Given this list of marker genes Rapsn, Stxbp1, Rab3a, P2rx3, Fchsd2, Rimbp3, Ntf3, Etv5, Fchsd1, Chrna4, Nlgn1 (neuroligin 1), Tspoap1, Cacna1a, Chrna5, Slc5a7, Chrna2, Rimbp2, Cd24a, Chrnb1, Chrnb4, Chrm1, Chrna1, Adarb1, Egr3, P2rx2, Chrna3, Chrna6, Stac3, Large1, Chrnb3, Mylk2, Kif1b, Vps54, Chat, Nrxn1, Chrnb2, here is a description of the gene set: species: Mus musculus The process of synaptic transmission from a neuron to a muscle, across a synapse. Mouse Gene Set: GOBP_NEUROMUSCULAR_SYNAPTIC_TRANSMISSION